Given this list of marker genes RCAN1, HERPUD1, SLC4A7, THBD, EGR2, PODXL, CD1B, PCTP, ANGPT2, PLPP3, MCM2, PTGS2 (prostaglandin-endoperoxide synthase 2), PPY, MRE11, CDR1, HBEGF, EGR3, A2M, BPI, here is a description of the gene set: Vascular endothelial growth factor (VEGF) is one of the most important factors that stimulate angiogenesis and vascular permeability. To clarify the role of VEGF, we analysed a human cDNA chip containing 7267 human genes to identify genes induced by VEGF in human umbilical vein endothelial cells (HUVECs). One hundred thirty-nine cDNAs, including ninety-nine previously known and forty poorly characterized or novel sequences, were increased more than two-fold by VEGF within twenty-four hours of stimulation. Among them, only five are known to regulate angiogenesis: cyclooxygenase 2 (COX2), heparin-binding epidermal growth factor-like growth factor, early growth response 1 (EGR 1), CYR61, and angiopoietin 2. Fifty-three genes induced within the first two hours were thought to be directly induced by VEGF. Of these, Down syndrome candidate region 1 (maximum induction = 6.1-fold) was the most profoundly induced, followed by Mifl (KIAA0025; 5.5-fold), COX2 (4.7-fold), EGR 3 (3.7-fold), EGR 2 (3.2-fold), bactericidal/permeability-increasing protein (3.1-fold), and CD1B antigen, b polypeptide (3.1-fold). In addition to the genes mentioned above, there were many poorly characterized or novel genes induced by VEGF. Further analysis of these genes may aid in the elucidation of the molecular mechanisms of angiogenesis or vascular permeability stimulated by VEGF. Human Gene Set: ABE_VEGFA_TARGETS from publication Abe M, Sato Y (PMID 12197474) Genes most profoundly induced in HUVEC cells (endothelium) by VEGFA. studied in species Homo sapiens